Given this list of marker genes Isy1, Hnrnpa3, Sarnp, U2af1, Prpf3, Hnrnpu, Hnrnpf, Rbm42, Sf3b3, Cdc5l, Lsm7 (NCBI Gene Id 68716), Wtap, Cpsf7, Snrnp48, Nup50, Eif4e, Polr2k, Cstf1, Srsf10, Ppil4, Zc3h11a, Polr2e, Syf2, Dhx16, Plrg1, Fyttd1, Dhx15, Sf1, Hnrnpr, Gtf2f2, Phf5a, Nup43, Zmat2 (NCBI Gene Id 73063), Ddx41 (DEAD box helicase 41), Mfap1a, Mtrex, Zcrb1, Yju2 (NCBI Gene Id 72886), Srsf7, Nup93, Sf3b5, Prpf4b, Usp39, Polr2c, Nxf2, Nup98 (NCBI Gene Id 330609), Snrnp70, Lsm6, Thoc2, Snrnp27, Cpsf3, Ppihl, Prpf6, Chtop, Cdc40, Snrpb, U2surp, Pcbp1, Ppil2, Sf3b2, Snip1, Polr2a, Dhx8, Ppwd1, Lsm4 (LSM4 homolog, U6 small nuclear RNA and mRNA degradation associated), Nxf1, Lsm5 (LSM5 homolog, U6 small nuclear RNA and mRNA degradation associated), Ncbp2, Aqr, Polr2d, Ranbp2 (RAN binding protein 2), Wdr70, Nup42, Sf3a1, Sf3b4, Snrnp25, Rae1, Hnrnpa2b1 (heterogeneous nuclear ribonucleoprotein A2/B1), Snrpd2, Bud31, Pdcd7, Cherp, Fam50a, Ncbp1, Ppil3, Nup107, Htatsf1, Alyref (NCBI Gene Id 21681), Hspa8, Prpf19, Srsf9, Rnps1, Pnn, Snrnp40, Polr2f, Clp1, Ctnnbl1, Lsm3, Rbm22, Zfp830, Pqbp1, Eftud2, Pabpn1, Polr2g, Prkrip1, Nup133, Hnrnph1, Prpf4, Leng1, Snrpg, Nup58, Snrpe, Rbm10, Sugp1, Nup210, Zmat5, Nup155, Ubl5, Tpr, Nup37, Prpf18, Sf3a2, Nup54, Nsrp1, Wbp11, Magoh, Cpsf1, Bud13, Ddx39b, Polr2l, Snrpn, Pcbp2, Hnrnpc, Hnrnpk, Gle1, Srsf1, Ddx5, Srrt, Steep1, Sec13, Nup88, Cwc15, Wbp4, Sde2, Nup160, Ik, Hnrnpd, Srsf11, Nup205, BC005624, Cstf3, Hnrnph2, Nudt21, Snrpd1, Tra2b, Srrm1 (serine/arginine repetitive matrix 1), Cpsf2, Slu7, Nxf7, Snrpa, Sf3b1, Slbp, Upf3b, Nup35, Srsf8, Luc7l3, Zrsr2, Gpatch1, Ddx46, Wdr33, Gpkow, Snrpb2, Rbm25, Eif4a3, Cwc22, Cpsf4, Rbm17, Papola, Srsf5, Rnpc3, Seh1l, Ccdc12, Nup188, Snu13, Fus, Dhx38, Thoc1, Hnrnpl, Aaas, Xab2, Cstf2t, Nup214, Ndc1, Prpf38a, Casc3, Snrnp200, Prpf40a, Rbm5 (NCBI Gene Id 83486), Acin1, Fip1l1, Fam32a, Cwc25, Gtf2f1, Srrm2, Ddx42, Ptbp1, Bcas2, Ddx23, Prcc, Thoc6, Sf3a3, Ybx1, Cactin, Rbmx, U2af1l4, Nxt1, U2af2, Rbm8a, Polr2i, Snrpa1, Prpf8, Poldip3 (polymerase (DNA-directed), delta interacting protein 3), Tcerg1, Srsf2, Smu1, Thoc7, Pcf11, Snrpd3, Polr2b, Sart1, Polr2h, Sympk, Rnf113a1, Mettl14 (methyltransferase 14, N6-adenosine-methyltransferase subunit), Nup153, Nup85, Pom121, Srsf3, Mettl3, Prpf31, Thoc3, Hnrnpa1, Cstf2, Dhx9, Cpsf6, Lsm2, Smndc1, Snrpc, Snrpf, Mfap1b, Ddx39a, Rbm39, Ppih, Nup62, Crnkl1, Rbm7, Lsm8, Snrnp35, Dhx35, Rbmx2, Cwc27 (CWC27 spliceosome-associated protein), Ppil1, Puf60, Nkap, Txnl4a, here is a description of the gene set: studied in species Mus musculus Processing of Capped Intron-Containing Pre-mRNA Mouse Gene Set: REACTOME_PROCESSING_OF_CAPPED_INTRON_CONTAINING_PRE_MRNA